The following is a description of a gene set: Regulation of lineage potential and transcriptional priming by Ikaros. New insight is provided into a bivalent regulation of lineage priming in the HSC and its lympho-myeloid restricted progeny the LMPP by the lymphoid lineage-determining factor Ikaros Whereas Ikaros is responsible for the activation of a cascade of lymphoid expression programs and for the establishment of lymphoid potential from the HSC to the LMPP it is also responsible for the repression of stem cell and erythroid genetic programs that are incompatible with further lineage restrictions emanating from the LMPP from publication Ng SY, Yoshida T, Zhang J, Georgopoulos K (PMID 19345118) species: Homo sapiens Genes down-regulated in hematopoietic stem cells versus lymphoid primed multipotent progenitors. Human Gene Set: GSE15330_HSC_VS_LYMPHOID_PRIMED_MULTIPOTENT_PROGENITOR_DN, and this is the list of marker genes: CEP55, HIP1, HPRT1, MAD2L1, ARSB, LAMC1, CHSY1, MTPN, RRBP1, TACC3, PSMD13, SPC25, FKBP5, S100A13, LMNB1, RPA2, ANXA1, MYL4, TBX21, CD48, APOBEC2, BHLHE40, RAD51, AURKA, IFITM1, RUNX2, EFHD2, COBLL1, CCR2, PRDX4, LAIR1, MYO1F, PRELID1, CDCA8, PSMD8 (proteasome 26S subunit, non-ATPase 8), DNAJB11, DAPK2, NCAPG2, FKBP2 (NCBI Gene Id 2286), AHNAK, ACOT7, IL18RAP, SNX10, PTGR1, RAP2A, PRR13, TPI1, KLRK1, ESM1, KLRC1, SLAMF7, IL18R1, LPIN2 (NCBI Gene Id 9663), BSG, SYTL2, PYCARD, ASF1B, CD38, COX5A, CRYBG1, ATOH1, HK2 (NCBI Gene Id 3099), NUP50, ALCAM (activated leukocyte cell adhesion molecule), LIG1, SERPINB9, MKI67, ITGB1, RAP1B, RAP1GAP2, DSTN, ORC6, ATP5IF1, CPD, NPTN, H4C9, L1CAM, GNPTAB, CPSF2, ZDHHC2, REEP5, ITGAM, GEM, ITGAL (NCBI Gene Id 3683), SYPL1, CD68, KIF11, MCM3, CCDC50, S100A11, MYADM, PTPN12, CXCR3, CCL4, NCAPG, CX3CR1, RRM1, PTTG1, PRDM1, GNG10, PPM1J, NIBAN1, MCM5, YBX3, ATP2B4, SGO2, OTULIN, GNG2, MFSD10, CXCR6, BAG1, ITGA1, CRIP1, ASRGL1, PRR11 (proline rich 11), H2BC4, S100A8, CENPH, SLC25A24, NCAPH (NCBI Gene Id 679), CHST11, PIK3AP1, PTPRJ, COX17, F2RL2, ATF6, DPCD, RNF216 (ring finger protein 216), GPR55, GALNT3, CTSD, MYO5A, FGL2, HTATIP2, SNX5, HMGN2 (high mobility group nucleosomal binding domain 2), OSBPL3, AIF1, RAB8B, PMAIP1, RFC3, RORA, BSCL2, DOCK5, CHPT1, NUDT4, CALM3, ENTPD1, SWAP70, HOPX, SEPTIN11, GGH, ESCO2, SAP30, VIM, AP3S1, MCM4, CALM1, CASP1, THEMIS2, NDUFB9, ANXA4, PLEK, NDUFB7, ZEB2, H1-0, ARHGAP18, MIS18BP1, INSL6, CD44, TPX2, PLAC8, KLRC2, GIMAP7, CENPE, ITGAX, IL12RB2, KNL1, STARD10, GSAP, SMPDL3B